The following is a description of a gene set: Genes having at least one occurrence of the motif NWWAACAAWANN in the regions spanning 4 kb centered on their transcription starting sites. This matches the SRY transcription factor binding site V$SRY_02 (v7.4 TRANSFAC). studied in species Homo sapiens Human Gene Set: SRY_02, and this is the list of marker genes: PPM1D, CSRNP3, DUSP6, STAG2, LINC03122, HSD11B1, MED8, PTN, PIK3R1, YWHAG, CDH9, USP32, CHN1, CRH, CILK1, CHD1, ELAVL2, TGFB3 (transforming growth factor beta 3), NFIB, MCM7, SOX2, ABCA6, TMEM50A, DLG2, CSNK1A1L, LRP5, RHOBTB1, PTGFRN, EMCN, PHF21A (PHD finger protein 21A), ZNF436, ANAPC15, DHX40, NRN1L, NFKBIE, RNF43, LINC01465, SGIP1, KANSL1L (NCBI Gene Id 151050), PAK1, DHRS3, TFAP4, TSC22D3, SALL3, NDNF, ZFYVE1, MYO18A, CCNJ, MLLT3, TFAP2B, MSI2, UCK2, RAPGEF5, CAMK1G, TCF4, SZT2 (SZT2 subunit of KICSTOR complex), ADGRL2, KLF7, TIAM1, TNRC6A, PCF11, SLITRK2, NFIX, ESRRG, APBA1, BAMBI, ADGRF1, MAGI3, LDB1, OPCML, KAT6A, CBFA2T2, CDC42EP3, NFE2L1, EIF4G2, GNAQ, EPHA7, FSBP, SRSF7, ZMYM2, MAB21L1, SOX5, IFIH1, KLHL13, SLC26A9, QKI, NPVF, NDP, FOXB1, SLC12A8, PALS2, KLF3-AS1, ZNF711, CREBRF, ATXN1 (NCBI Gene Id 7912), CLIP2, DIP2B, NUDT11, PAK3, TCF15, STC1, HOXD10, NR4A3, PPP2R2B, OLFM1, IKZF2, SREK1, TIAL1, HESX1, SLC7A1, ZBTB22, SEMA6C, TBX5, RBBP4, ZNF668, VCPKMT, KRT13, CD36, PTGR3, RBM8A, WASL, RBFOX2, FAM53B, FGF9, NECAP1, ALDH1A2, ZBTB8OS, CXCL17, INHBA, ZBED10P, MDGA1, PRKAG1, FOXP2, MRC2, DDX6, GATA2, DCHS1, MAP1B, MXI1, HLX, MACROH2A1, FOXO4, GRAP, HS3ST1 (NCBI Gene Id 9957), DUSP5, KYAT1, LYST, KBTBD2, CCDC92, TBX6, KAT14, ARHGAP15, LRRN1, NR4A1, ZC3H6, ELAVL4, ZNF362, LMO4, LEMD1, CACNA1E, HOXC4, PUM1, OLFML3, ZNF646, MYLK, PLEKHA5, NTF3, ZEB2, CPNE1, PDZRN4, GNAO1 (G protein subunit alpha o1), MAML1, AP4M1, NKX2-2, MAML3, DTNA, NFIA, CTTNBP2NL, RELT, SOX6, NIPBL, PELI2, UBR5, NSF, E2F1, B3GALT2, NR3C2, G3BP2, KERA, NREP, MOBP, ANGPT1, POU3F4, KCNN2, EBF1, TMEM196, ZNF385B, FGFR2, PURA, IL5RA, EN2, KLHL41, FN1, PREX2, SP8, HEY1, NRP1, ZBED5, RCN1, RBFOX1, XKRX, ZNF664 (NCBI Gene Id 7729), LRP1, PSMA8, SLC13A1, SATB1, ULK1, JADE3, TMEM179, DLL1, C21orf91, BNC2, HNF1A, CSRNP2, KLF3, IL25, CFL2, FST, FBN2 (NCBI Gene Id 877), MTCL2, CADM1, SIX4, AP1G2, ZNF436-AS1 (NCBI Gene Id 148898), COMMD3, TECTA, CTLA4, NANOS1, ACVR2A, LRCH2, HOXB5, PIK3CG, ZIC2, PIAS1, SMAD3, CLDN18, MGAT4C, ZBTB37, RTL9, CTNNB1, MID2, POU4F1, SCRT2, TACSTD2, EBF2, MITF, MBNL2, CASC2, TNFRSF19